The following is a description of a gene set: studied in species Mus musculus Mouse Gene Set: chr3F3, and this is the list of marker genes: Gm17954, Aknad1, Slc25a54, Gm5548, Amy2a3, Gm38395, Prpf38b, Olfm3, Gm6602, Gm23750, Gm25681, Henmt1, Gm12517, Fndc7, Amy2a2, Gm19185, Rnpc3, Gm19391, Gm43405, Amy2b, Amy2a5, Gm43221, Cfap276, Tmem167b, Gpsm2, Gm4859, Gm13865, Elapor1, Eeig2, Col11a1, Utp14b-ps1, Wdr47, Gm18163, Gm22942, 4930408K08Rik, Taf13, Gm12522, Scarna2, Celsr2, Slc25a24, Sars1, Gm23336, Amy2a1, Amy2a4 (amylase 2a4), Gm9314, Gm25519, Vav3, Clcc1, Amy1, Gm9857, Mybphl, C130013H08Rik, Gm9317, Gm19147, Prmt6, Amy2-ps1, Stxbp3, Psrc1, Gm17775, Ntng1